The following is a description of a gene set: Genes having at least one occurence of the motif GTTAAAG in their 3' untranslated region. The motif represents putative target (that is, seed match) of human mature miRNA hsa-miR-302b* (v7.1 miRBase). Human Gene Set: GTTAAAG_MIR302B species: Homo sapiens, and this is the list of marker genes: BMAL1, WNT3, DYNLT5, POU3F2, SIPA1L2, KHDRBS1 (NCBI Gene Id 10657), BCL6, NLK, ACVR1, LPIN1, ATP2C1, ARID4B, DOLPP1, RANBP2, GGNBP2, ATXN1, PLAGL2, EPC2, PCDH9, TMEM45A, FAM168B, HOXA5, PDK2, SMAD3, LRRN1, AP1G1, FMR1, CNBP, ASXL1, SLC9A6, TRAF7, CTNND2, PAXIP1, MINDY3, ING3, TIPARP, ST8SIA2, C5orf24, NRXN3, SRSF2, AFF4, GRB2, VSTM2A, SYNJ1, SPAST, ALCAM, DDA1, DAZAP1, MLEC, LCLAT1, R3HCC1L, PDGFRA, PRRX1, CPEB2, SLC26A9, GAD1, STAG2, MOB3B, NRP1, FAM210A, ROBO2, KPNA3, AP1S1, KCNMA1, PURB, PKP1, TM4SF19, ANK2, RAB14